The following is a description of a gene set: Hemorrhage occurring within a joint. species: Homo sapiens Joint hemorrhage Human Gene Set: HP_JOINT_HEMORRHAGE, and this is the list of marker genes: F13A1 (NCBI Gene Id 2162), GGCX, F13B, MCFD2, SERPINE1, LMAN1, VWF, WAS, SERPINF2, F9, F10, F7, PLAU, F2, F5, F11, F8